The following is a description of a gene set: Marcus Gunn jaw winking synkinesis Unilateral ptosis with associated upper eyelid contraction and contraction of either the external or the internal pterygoid muscle. It is thought to occur because of congenital miswiring of a branch of the fifth cranial nerve into the branch of the third cranial nerve supplying the levator muscle. In Marcus Gunn jaw winking synkinesis, elevation and even retraction of the affected eyelid is triggered by chewing, suction, lateral mandible movement, smiling, sternocleidomastoid contraction, protruding tongue, Valsalva maneuver and even by breathing. Human Gene Set: HP_MARCUS_GUNN_JAW_WINKING_SYNKINESIS species: Homo sapiens, and this is the list of marker genes: KDM6A, TOGARAM1, CHN1, PHOX2A, SALL4, MAFB, TUBB2B, COL25A1, KIF21A, WDR26, TUBB3, KMT2D, TUBA1A